The following is a description of a gene set: Human Gene Set: GOCC_PYRUVATE_DEHYDROGENASE_COMPLEX studied in species Homo sapiens A multi-enzyme complex that catalyzes the oxidative decarboxylation of pyruvate to form acetyl-CoA. The complex comprises multiple copies of three enzymes referred to as E1, E2 and E3: pyruvate dehydrogenase (E1, which may be a homodimer or a heterotetramer of two alpha and two beta subunits, depending on species), dihydrolipoamide S-acetyltransferase (E2), and dihydrolipoamide dehydrogenase (E3). Additional proteins may also be present., and this is the list of marker genes: DLAT, DLD, PDHX, PDHA1, PDK1, PDK2, PDHA2, PDHB